The following is a description of a gene set: RNA polymerase II, one of three nuclear DNA-directed RNA polymerases found in all eukaryotes, is a multisubunit complex; typically it produces mRNAs, snoRNAs, and some of the snRNAs. Two large subunits comprise the most conserved portion including the catalytic site and share similarity with other eukaryotic and bacterial multisubunit RNA polymerases. The largest subunit of RNA polymerase II contains an essential carboxyl-terminal domain (CTD) composed of a variable number of heptapeptide repeats (YSPTSPS). The remainder of the complex is composed of smaller subunits (generally ten or more), some of which are also found in RNA polymerases I and III. Although the core is competent to mediate ribonucleic acid synthesis, it requires additional factors to select the appropriate template. studied in species Mus musculus Mouse Gene Set: GOCC_RNA_POLYMERASE_II_CORE_COMPLEX, and this is the list of marker genes: Polr2d, Tuft1, Polr2l, Polr2h, Polr2j, Polr2k, Polr2b, Polr2a, Polr2g, Polr2c, Polr2i, Polr2e, Polr2f, Myzap, Polr2m